Given this list of marker genes Angptl3, Anxa3 (annexin A3), Ppt1, Apoc1, Anxa2, Pinlyp, Anxa1, Scgb1a1, here is a description of the gene set: species: Mus musculus Binds to and stops, prevents or reduces the activity of a phospholipase, an enzyme that catalyzes of the hydrolysis of a phospholipid. Mouse Gene Set: GOMF_PHOSPHOLIPASE_INHIBITOR_ACTIVITY